The following is a description of a gene set: species: Mus musculus The chemical reactions and pathways involving glucosamine (2-amino-2-deoxyglucopyranose), an aminodeoxysugar that occurs in combined form in chitin. Mouse Gene Set: GOBP_GLUCOSAMINE_METABOLIC_PROCESS, and this is the list of marker genes: Gnpda1, Ogt, Gnpda2, Gfpt1, Gnpnat1